The following is a description of a gene set: species: Homo sapiens Human Gene Set: WP_CYTOSOLIC_DNASENSING_PATHWAY Cytosolic DNA-sensing pathway, and this is the list of marker genes: CASP8, POLR2F, NLRX1, CASP1, CGAS (NCBI Gene Id 115004), IFNA13, IL6, RIPK3, STING1, POLR2K (NCBI Gene Id 5440), RIGI, TRIM25, NFKBIA, CCL5, POLR3K, CYLD, IL33, POLR3C, POLR3F, IFNB1, ADAR, ATG5, RELA, POLR2L, POLR3D, IL1B, IKBKE, IFNA17, IRF3, POLR3G, CXCL10, IL18, IFNA1, CCL4L2 (C-C motif chemokine ligand 4 like 2), MAVS, POLR3A, CHUK, IFNA21, POLR2H, POLR1C (RNA polymerase I and III subunit C), CCL4, RNF125, IKBKG, IFNA2, IRF7, TRADD, TBK1, RIPK1, IFNA6, POLR3B, IFNA7, PYCARD, IFNA4, POLR1D, TREX1, POLR3GL, NFKBIB, POLR3H, NFKB1, ISG15, FADD, ATG12, IKBKB, IFNA5, IFNA8, POLR3E, POLR2E, ZBP1, IFNA14, CASP10, AIM2, IFNA10 (interferon alpha 10), IFNA16